Given this list of marker genes PLBD1, CASP1, LILRB3, ADA2, AP1S2, FOS, PSAP, HCK, CFP, CPVL, TBXAS1, IGSF6, MAFB, CD14, RNF130, MS4A6A, FCN1, TYROBP (transmembrane immune signaling adaptor TYROBP), CLEC4A (C-type lectin domain family 4 member A), LILRA1, CPPED1, TLR2, DUSP1, COTL1, CD33, CD86, VNN1, LILRB2, AIF1, TNFAIP2 (NCBI Gene Id 7127), FGL2, TNFRSF1B, HK3, SLC7A7, CD302, NOD2, PYCARD, CD1D, STX11, TYMP, CYBB, CTSS, LILRA6, RGS2, LILRA3, here is a description of the gene set: Human Gene Set: GNF2_CD1D Neighborhood of CD1D CD1d molecule in the GNF2 expression compendium species: Homo sapiens Neighborhood of CD1D